The following is a description of a gene set: The series of molecular signals initiated by an extracellular ligand binding to the receptor Notch on the surface of a target cell, and ending with the regulation of a downstream cellular process, e.g. transcription. Human Gene Set: GOBP_NOTCH_SIGNALING_PATHWAY species: Homo sapiens, and this is the list of marker genes: YTHDF2, MAML2 (NCBI Gene Id 84441), HEYL, APH1B, NEURL1, MAML3, TMEM100, FOXC2, HES7, BCL6, SIX1, GATA5, EPN2, CNTN1, TGFB2, ONECUT1, SOX9, NRARP, POGLUT1, MIR1224, CDK6, NOTCH4, APP, MECP2, PLN, ZNF423, POSTN, HEY2, HERC2, TSPAN5, CFAP58 (NCBI Gene Id 159686), BEND6, HES1, PRKCI, DTX4, ROBO1, TIMP4, DLX1, NFKBIA, GALNT11, NKAP, SNAI1, HIF1AN (NCBI Gene Id 84175), ITGB1BP1, SNAI2, DTX1, AKT1, GSX2, RFNG, AGXT, DLL4, MAML1, IL6ST, POFUT1, CDH6, LFNG, NOS3, MESP1, MIR141, TCIM, EPN1, STAT3, IFT172, WWP2, ACVRL1, TM2D3, MMP14, NCSTN, KIT, NRIP2, NR1H4, NOTCH2NLA, GAS2, ROBO2, MIB1, PSENEN, NLE1, NOTCH3, ETV2, DLL3, HOXD3, CCNC, MESP2, DNER, PGAM2, NOTCH2, SRC, FOXC1, MIB2, PRAG1, MFNG, DLL1, NEUROD4, GOT1, SEL1L, ENHO, CNTN6, CBFA2T2 (NCBI Gene Id 9139), NEURL1B, MIR212, PTP4A3, CCDC85C, CDKN1B, DLK1, DTX3L, TSPAN14, SLC35C2, IFT74, NOTCH2NLC, DTX2, LRRK2, IL2RA, PERP, RIPPLY2, GDF2, SUSD5, HEY1, WNT1, ADAM10, LLGL1, RITA1, ASCL1, FOXA1, CEBPA, CTBP1, DLK2, BMP7, FGF10, JAG2, SPEN, WDR12, METTL3 (NCBI Gene Id 95719), PDCD10, ZBTB7A, TP63, TGFBR2, NEPRO, CDK3, NR0B2, BMP2K, GMDS, SREBF2, GRIP2, GATA2, RCAN2 (NCBI Gene Id 221402), EGFL7, RBM15, RBPJ, KRT19, BMP2, FBXW7, TBX2, HNF1B, ADAM17, CD46, NOD2, DLX2, TGFB1, YJEFN3, CHAC1, PSEN1, ANGPT4, IL17A, TSPAN15, DTX3, ARRB1, ATOH1, HES5, TSPEAR, JAG1, SYNJ2BP, MIR126, ANXA4 (annexin A4), TTYH1, MAGEA1, S1PR3, SORBS2, MIR200C (NCBI Gene Id 406985), YAP1 (NCBI Gene Id 10413), OVOL2, PSEN2, APH1A, AAK1, NOTCH1, ARRDC1, CCN3, SLC35C1, LLGL2, ZMIZ1, KCNA5, NOTCH2NLB